The following is a description of a gene set: species: Homo sapiens Human Gene Set: GOMF_RIBOSOMAL_PROTEIN_S6_KINASE_ACTIVITY Catalysis of the reaction: ribosomal protein S6 + ATP = ribosomal protein S6 phosphate + ATP., and this is the list of marker genes: RPS6KA3, RPS6KA1, RPS6KA2, RPS6KA6, RPS6KA4, RPS6KB2